Given this list of marker genes CST3, DLL3, HOPX, TLK1, RARRES2, SEZ6, PANTR1, ETV1, here is a description of the gene set: Human Gene Set: ZHONG_PFC_C3_HOPX_POS_OPC from publication Zhong S, Zhang S, Fan X, Wu Q, Yan L, Dong J, Zhang H, Li L, Sun L, Pan N, Xu X, Tang F, Zhang J, Qiao J, Wang X (PMID 29539641) species: Homo sapiens